Given this list of marker genes CD2AP, SYT4, FBXO28, ZNF138, PLCB4, STIL, DDX3X, LHX8, PAPOLA, ZSWIM6, NAALADL2, KIAA1958, LACC1, SMC3, RECK, HNRNPUL1, TMEM131, RGN, CTDSPL2, JAM2, SLCO1A2, PPM1M, FOXN2, ARFGEF1, SLC4A5, MFSD14B (major facilitator superfamily domain containing 14B), SLC26A3, SLC16A7, SYT1, NRK, HNRNPD, NOL4, PPTC7, TOP1, GPR176, ARIH2, FUNDC1, NPHP1, VMP1 (NCBI Gene Id 81671), SLC17A6, RSPO4, SMCO3, CASP3, PIAS2, BLTP3A, SOD2, SLC45A4, PRPS2, UQCRB, TSPAN2, ATP5F1C, SBNO1, ARID5B, IFNA2, AGPS, SDK1, FSTL5, STXBP4, COL19A1, VSNL1, here is a description of the gene set: Genes predicted to be targets of miRBase v22 microRNA hsa-miR-382-5p in miRDB v6.0 with MirTarget v4 prediction scores > 80 (high confidence targets). from publication Chen Y, Wang X (PMID 31504780) Human Gene Set: MIR382_5P species: Homo sapiens